Given this list of marker genes Rcsd1, Trio (NCBI Gene Id 77730), Haus8, Icosl, Tnfrsf1b, Slc6a6, here is a description of the gene set: Genes negatively differentially expressed in cell type: Langerhans upon treatment with cytokine: TSLP in mouse lymph nodes in vivo. Mouse Gene Set: CUI_LANGERHANS_TSLP_RESPONSE_DN from publication Cui A, Huang T, Li S, Ma A, Pérez JL, Sander C, Keskin DB, Wu CJ, Fraenkel E, Hacohen N (PMID 38057668) species: Mus musculus Cytokines mediate cell-cell communication in the immune system and represent important therapeutic targets. A myriad of studies have highlighted their central role in immune function, yet we lack a global view of the cellular responses of each immune cell type to each cytokine. To address this gap, the authors created the Immune Dictionary, a compendium of single-cell transcriptomic profiles of more than 17 immune cell types in response to each of 86 cytokines (>1,400 cytokine-cell type combinations) in mouse lymph nodes in vivo. A cytokine-centric view of the dictionary revealed that most cytokines induce highly cell-type-specific responses. For example, the inflammatory cytokine interleukin-1β induces distinct gene programmes in almost every cell type. A cell-type-centric view of the dictionary identified more than 66 cytokine-driven cellular polarization states across immune cell types, including previously uncharacterized states such as an interleukin-18-induced polyfunctional natural killer cell state.